The following is a description of a gene set: Mouse Gene Set: GOBP_ORGANOHALOGEN_METABOLIC_PROCESS species: Mus musculus The chemical reactions and pathways involving organohalogen compounds, as carried out by individual cells., and this is the list of marker genes: Ugt1a6a, Por, Ugt1a6b, Cyp2f2, Gstt1